The following is a description of a gene set: studied in species Homo sapiens The presence of a malformed cochlea. Cochlear malformation Human Gene Set: HP_COCHLEAR_MALFORMATION, and this is the list of marker genes: KCNJ10, HAAO, SLC26A4, SRCAP, EYA1 (EYA transcriptional coactivator and phosphatase 1), SIX1, EBF3, COL4A6 (NCBI Gene Id 1288), FOXI1, PI4KB, ORC1